The following is a description of a gene set: Human Gene Set: GOCC_PHAGOCYTIC_CUP An invagination of the cell membrane formed by an actin dependent process during phagocytosis. Following internalization it is converted into a phagosome. species: Homo sapiens, and this is the list of marker genes: ANXA1, CORO1A, SH3BP1, PEAR1, TNF, ABCA7, TICAM2, TLR4, RAB31, ARHGAP25, IRGM, DNM2 (dynamin 2), RACK1, CLEC4E, MEGF10, ARHGAP12, ADGRB1, RAB11FIP2 (RAB11 family interacting protein 2), CDC42SE2, AIF1, BIN2, AGER, MCOLN1, RAC1, PIP5K1C, SYT11, LCP1, MYO1G, SNX5, TRIP10